Given this list of marker genes PHF21A, BCL11A, DDIT4, HOXC6, TMEM88, ZNF768, ELMO1, ELAVL4, TWIST1, ZIC3, PPP1R1B, FZD5, ZBTB18, RBMS2, MPPED2, IKBKB, APPL2, SLC12A4, PYM1, TFEB, JUND (NCBI Gene Id 3727), ZHX2, GAS2L2, ATP8A2, WNT3, EGR3, GSE1, SKAP2, FBXL19, DDAH2, GFRA3, KIF3B, DALRD3, RETREG1, KCNN3, ZFYVE26, TNFRSF1A, KCNQ1DN, RGS14, ST8SIA2, HBEGF, CAMK2D, SREBF2, SLC9A6, JARID2, SDF2, BAHD1, ENSA, GGNBP2, GABRA1, SUMO2, DLX1, ARF6, BCL2L1, NXPH4, ARHGAP1, PACC1, ZNF23, TUSC3 (tumor suppressor candidate 3), WDFY4, SP6 (NCBI Gene Id 80320), OLFM4, PIK3CD, EMP1, IRAK1, PIK3IP1, CTBP2, CAST, DPYSL2, BHLHE41, KRTAP23-1, NFATC1, RASGRP2, RTL3, PTBP2, EBAG9, MIDEAS, ERBIN, MAP3K4, ADAM15 (ADAM metallopeptidase domain 15), ANTKMT, ZIC4, MOAP1, AKAP12, FSHB, ZMYM2, ACIN1, LINC03124, PDCD10, S100A16, PRDM13, ASCL1, PML, MAP4K2, RFX2, KMT2A, ALDH16A1, PRKAG2, RHOV, GEMIN8, PHF23, BORA, STARD13, JUNB, PREX1, SLITRK1, VAX1, NDNF, ZBTB9, NEUROG1, LHX6, FBRS, ZNF800, EFNB3, KCNT2 (NCBI Gene Id 343450), PNOC, CA11, SHISA6, GATB, SUPT6H, GATA1, HOXC4, HMGCS1, MLLT6, PICALM, AAMP, SIRT3, FGF12, CSMD3, BEST2, ZNF408, WNT4, EPHB1, CANX, FBXL19-AS1, NKX6-2, PPP3CA, DMD, LTBR, MYCL, DGKA, TMEM47, ING2, BMERB1, GJB1, E2F3, HEBP1 (NCBI Gene Id 50865), PDRG1, KCNAB2, SRPK2, CHD4, TOR4A, C1orf43, RARG, SLITRK5, PPP3CB, LBX1, TRIM3, WDTC1, PIH1D1, ANKS1B, SERPINI1, SYNCRIP, C14orf119, SLC44A1, MTA2, STAG2, PHC3, FGFR1, NDUFAF3, TNRC6A, TFAP2D, RARA, CSRNP2, WNT10A, ARAP1, EMCN, EPN3, CKS1B, MAML3, HOXA2, GRK5, PLP1, RERE, TNFRSF12A (NCBI Gene Id 51330), RORC, POLD4, PRKACB, CRIM1, PRRG1, ARL4C, CFAP161, GSN, CXXC5, ESRRG, NLGN3, OMA1 (OMA1 zinc metallopeptidase), ZIC1, DMTF1, ORAI3, CDK17, WNT7B, PUM2, NPR1, ZMAT3, ZMYND8 (NCBI Gene Id 55497), PSMD13, CHMP1B, FOXP1, JADE3, MACO1, APH1A, BLCAP, PPP1CB, GRM7, INTS7, CACNB2, SMPD3, GJB2, LDOC1, PNKD, KCNH3, WNT11, TRIM55, NME1, ARMC6, FURIN, GPLD1, TSC22D3, TSPAN6, HTN1, NR2F1, SUGP2, GDNF, CARMIL3, CCDC88A, PCDHAC2, PPP4C, SYN1, DPP3, NLK, HCN3, DPF3, CDK15, ORAI1, POMP, ZNF395, SIX4, SHC1, INHA, SEMA4C, EDEM2, NFKBIA, FDPS, FNBP1L, GPC3, here is a description of the gene set: Human Gene Set: P300_01 species: Homo sapiens Genes having at least one occurrence of the motif NNNGGGAGTNNNNS in the regions spanning 4 kb centered on their transcription starting sites. This matches the PCAF transcription factor binding site V$P300_01 (v7.4 TRANSFAC).